The following is a description of a gene set: Reactome Pathway: Scavenging by Class A Receptors electronically inferred by orthology from the curated human pathway This event has been computationally inferred from an event that has been demonstrated in another species.<p>The inference is based on the homology mapping from PANTHER. Briefly, reactions for which all involved PhysicalEntities (in input, output and catalyst) have a mapped orthologue/paralogue (for complexes at least 75% of components must have a mapping) are inferred to the other species. part of: Binding and Uptake of Ligands by Scavenger Receptors studied in species Mus musculus, and this is the list of marker genes: Calr, Hsp90b1, Colec11, Apoe, Apoa1, Masp1, Apob, Msr1